The following is a description of a gene set: studied in species Mus musculus Any process that activates or increases the frequency, rate, or extent of T cell mediated immunity. Mouse Gene Set: GOBP_POSITIVE_REGULATION_OF_T_CELL_MEDIATED_IMMUNITY, and this is the list of marker genes: Cd55b, P2rx7, H2-D1, B2m, Rsad2, Raet1d, H2-T24, H2-Q7, H2-Q4, H2-M10.4, Hspa8, Il4, Raet1e, H2-M5 (NCBI Gene Id 630349), Prkcz, H2-M9, H2-Q1, Gata3, H2-M10.2, Il1b, Tbx21, Malt1, 2410137M14Rik, H2-M10.1, Il12a, Il23a, H2-Q2, H2-M2, Mr1, H2-K1, Dennd1b, Ulbp1, H2-Q6, Cd1d2, H2-T22, H2-M3, Xcl1, Traf2, Fadd, H2-M10.5, Klhl22, Slamf1, Pvr, Map3k7, Il12b, Il18r1, H2-T15, Sash3, Cd81, Nlrp3, Stx7, Pnp, H60b, Nectin2, Traf6, Cd55, Fbxo38, Cd24a, Il18, Foxp3, Il6, Zbtb1, Arid5a, Fzd5, H2-M11, H2-T13, Azgp1, Hspd1, Ptprc, Ywhag, H2-T23, Prkaa1, Tap2 (transporter 2, ATP-binding cassette, sub-family B (MDR/TAP)), Tnfsf4, Slc22a13, H2-M10.6, H2-T3, Zp3, Cyrib, H60c, Cd1d1, H2-M1, H2-Q10, H2-Ea, H2-M10.3, Il1r1 (interleukin 1 receptor, type I), H2-T5